Given this list of marker genes AKT1 (AKT serine/threonine kinase 1), APC, JUP, BCL9, LEF1, GSK3B, FLT3, LRP5 (NCBI Gene Id 8058), PPARD, CSNK1A1, TCF3, DKK1, AXIN2, RARA, CCND1, CTNNB1, SALL4, WIF1, LRP6, PML, RUNX1T1, ZBTB16, FZD6, WNT1, MYC, PYGO1, here is a description of the gene set: studied in species Homo sapiens Human Gene Set: WP_WNTBETACATENIN_SIGNALING_IN_LEUKEMIA Wnt/beta-catenin signaling in leukemia